Given this list of marker genes Timm17b, Grpel1, Pam16, Tomm20l, Tomm7, Timm44, Dnajc19, Dnlz, Tomm70a, Tomm20, Timm23 (NCBI Gene Id 53915), Tomm40l, Grpel2, Tomm40, Dnajc15, Romo1, Timm21, Timm17a, Timm50, here is a description of the gene set: The import of proteins across the outer and inner mitochondrial membranes into the matrix. Unfolded proteins enter the mitochondrial matrix with a chaperone protein; the information required to target the precursor protein from the cytosol to the mitochondrial matrix is contained within its N-terminal matrix-targeting sequence. Translocation of precursors to the matrix occurs at the rare sites where the outer and inner membranes are close together. species: Mus musculus Mouse Gene Set: GOBP_PROTEIN_IMPORT_INTO_MITOCHONDRIAL_MATRIX